Given this list of marker genes COL1A1, LTBP2 (latent transforming growth factor beta binding protein 2), NMRK2, IGFBP7, COL5A2, COL1A2, CCN5, APOD, ELN, SVEP1, RCAN1, LOX, BGN, POSTN (periostin), ASPN, CRLF1, LUM, TGFB3, here is a description of the gene set: Human Gene Set: THUM_MIR21_TARGETS_HEART_DISEASE_UP MicroRNAs comprise a broad class of small non-coding RNAs that control expression of complementary target messenger RNAs. Dysregulation of microRNAs by several mechanisms has been described in various disease states including cardiac disease. Whereas previous studies of cardiac disease have focused on microRNAs that are primarily expressed in cardiomyocytes, the role of microRNAs expressed in other cell types of the heart is unclear. Here we show that microRNA-21 (miR-21, also known as Mirn21) regulates the ERK-MAP kinase signalling pathway in cardiac fibroblasts, which has impacts on global cardiac structure and function. miR-21 levels are increased selectively in fibroblasts of the failing heart, augmenting ERK-MAP kinase activity through inhibition of sprouty homologue 1 (Spry1). This mechanism regulates fibroblast survival and growth factor secretion, apparently controlling the extent of interstitial fibrosis and cardiac hypertrophy. In vivo silencing of miR-21 by a specific antagomir in a mouse pressure-overload-induced disease model reduces cardiac ERK-MAP kinase activity, inhibits interstitial fibrosis and attenuates cardiac dysfunction. These findings reveal that microRNAs can contribute to myocardial disease by an effect in cardiac fibroblasts. Our results validate miR-21 as a disease target in heart failure and establish the therapeutic efficacy of microRNA therapeutic intervention in a cardiovascular disease setting. studied in species Mus musculus Genes up-regulated in a mouse model of heart disease whose expression reverted to normal by silencing of MIR21 microRNA. from publication Thum T, Gross C, Fiedler J, Fischer T, Kissler S, Bussen M, Galuppo P, Just S, Rottbauer W, Frantz S, Castoldi M, Soutschek J, Koteliansky V, Rosenwald A, Basson MA, Licht JD, Pena JT, Rouhanifard SH, Muckenthaler MU, Tuschl T, Martin GR, Bauersachs J, Engelhardt S (PMID 19043405)